Given this list of marker genes Uba7, Ifi44l, Isg15, Ikbkg, Trim25, Ube2l6 (NCBI Gene Id 67250), Arih1, Fkbp5, Ifi44 (NCBI Gene Id 99899), Rigi, Ikbkb, Chuk, here is a description of the gene set: species: Mus musculus Mouse Gene Set: REACTOME_MODULATION_OF_HOST_RESPONSES_BY_IFN_STIMULATED_GENES Modulation of host responses by IFN-stimulated genes